The following is a description of a gene set: Human Gene Set: GOBP_POSITIVE_REGULATION_OF_MITOCHONDRIAL_FISSION species: Homo sapiens Any process that increases the rate, frequency or extent of mitochondrial fission. Mitochondrial fission is the division of a mitochondrion within a cell to form two or more separate mitochondrial compartments., and this is the list of marker genes: PINK1, MIEF1, MIEF2, RALBP1, RALA, DDHD1, FIS1, BNIP3, MUL1, KDR, DCN, VPS35 (NCBI Gene Id 91808), PGAM5, AURKA, MARCHF5, MCU, DDHD2, SPIRE1, IRGM, MFF, DNM1L, PRKN